The following is a description of a gene set: from publication Orabona C, Puccetti P, Vacca C, Bicciato S, Luchini A, Fallarino F, Bianchi R, Velardi E, Perruccio K, Velardi A, Bronte V, Fioretti MC, Grohmann U (PMID 16339401) Although much is known on the transcriptional profiles of dendritic cells (DCs) during maturation, the molecular switches critical for the acquisition of a tolerogenic program by DCs are still obscure. In the present study, we explored the gene expression pattern of CD8+ DCs purified from the mouse spleen and treated with interferon (IFN)-gamma. The cytokine, indeed, potentiates the tolerogenic potential of this DC subset via induction of the immunosuppressive tryptophan catabolism mediated by indoleamine 2,3-dioxygenase (IDO). By comparing the expression of the IFN-gamma-modulated genes in IDO+ versus IDO- murine DCs, we found a consistent and selective association of the IDO-competent phenotype with the down-modulation of the Tyrobp gene, encoding the adapter molecule DAP12. IFN-gamma-mediated down-modulation of this gene involved IFN consensus sequence binding protein (ICSBP), a transcription factor also known as IRF-8. While silencing of Tyrobp conferred IDO functional competence on IDO- DCs, silencing of Icsbp1 in IDO+ cells completely abolished IDO expression and function. In parallel, silencing of TYROBP conferred IDO competence on human IDO- DCs while silencing of IRF8 impaired IDO expression and activity in human IDO+ DCs. Therefore, the same small set of molecular switches controls IDO competence in murine and human DCs. Genes up-regulated in comparison of untreated CD8+ dendritic cells (DC) at 4 h versus those treated with IFNG at 16 h. Human Gene Set: GSE3337_4H_VS_16H_IFNG_IN_CD8POS_DC_UP studied in species Homo sapiens, and this is the list of marker genes: MRPL46, COPS8, TCP1, RNASEH2A, RNPS1, DBT, CDT1, NANS, ZNF688, PRELID3B, LSP1, GADD45G, ATP6V0A1, CPSF7, PPIF, ZFP36, GHITM, GPD2, IL1R2, SPSB1, GNAI3, SHMT1, GADD45B, HDLBP, GOSR1, ADK, ANKRD33B, IMP4, MCM2, PCLO, ACOT7, AAMP, RBM6, RELB (RELB proto-oncogene, NF-kB subunit), SEC13, IL4I1, MCM5 (minichromosome maintenance complex component 5), SERPINB1, PSMD4, ZC3HC1, RNF19B, BUD31, POLR2I, ASPRV1, FASLG, CRNKL1, CHKA, SIVA1, PRIM1, TNFRSF18, PPIH, TSPAN33, SNRPG, PRRC1, COPS7A, WDR55, GPR137B, ADPRS, PRNP, GPN3, CDKN1A, HSPA4, PSMB2, NEK6, PSMC1, CD80, YWHAE, DDX21, TNIP1, LIMA1, ADAM8, FBXO45, LAPTM4B, STAM2, SUPV3L1, CD1D (NCBI Gene Id 912), LARS1, MEMO1 (NCBI Gene Id 63983), PPA1, GLIPR2, MRPL2, PFKFB3, COPS2, SLC44A1, NPM3, PLK2, SUB1, NUP85, HSP90AB1, DDX19B, CD83, SLC1A5, HAX1, NAA38, NASP, FOXN2, EDF1, NUP62, IRF6, CXCL10, CD40, MRPL34, PSMC5, RRM1, SART3, IFI30, GALK1, NOP56, DR1, TMEM97, MAT2A, STAT3, TP53INP2, LMNA, RAMP3, AURKAIP1, PDZD11, AGO2, IPO11, BATF3, CDK11B, TK1, HBA2, TNFAIP3, GAR1, SLFN12, MRPL20, PSMB6, GRAMD2B, FAM216A, NFE2L1, TNF, ENO2, RUVBL2, SFPQ, HSPA1A, GLCE, TMEM147, MYO10, EIF4EBP1, RAN, METTL9, IDE, SPIC, SELENOK, ST7, ABCC1, EMC8, ELOVL2, SPHK1, EIF6, TAMM41, ZSCAN21, KPNA3, TNFAIP2, UFD1 (NCBI Gene Id 7353), GABARAPL1, PEBP1 (phosphatidylethanolamine binding protein 1), GTF2B, NELFE, SNAP47, GADD45A, AGRN, DDIT3, ENO3, LDHA, MAFK, CARS1, SRGN (NCBI Gene Id 5552), BIRC3, POLB, MRTO4, UCK2, MORF4L2, GCLC, ENSA, LSM4, IL1RN, MT1E, CCT3, NUDT5, CD63, IFNG (NCBI Gene Id 3458), CLPP, DNAJA2, CCR7, PTGER4, SRI, HBB, DPH5, TRAF1, MRPL23, WDR43, TIPIN, HNRNPAB, EIF3L, NDRG1, METTL3, EIF4A3, CSNK1D